The following is a description of a gene set: The change in morphology and behavior of a gamma-delta T cell resulting from exposure to a mitogen, cytokine, chemokine, cellular ligand, or an antigen for which it is specific. species: Homo sapiens Human Gene Set: GOBP_GAMMA_DELTA_T_CELL_ACTIVATION, and this is the list of marker genes: NCKAP1L, JAML, KLRC1, STAT5B, LCK (NCBI Gene Id 95387), LEF1, NOD2, ITK, CD247, SYK, SOX4, TCF7, CXADR, MICB, GPR18, CD3E, LILRB1, CCR9, MICA, EGR3, SOX13, ALKBH5, TRDC, JAG2, PTPRC, CD3G, TRGC1, STAT5A